The following is a description of a gene set: Signaling by ALK Mouse Gene Set: REACTOME_SIGNALING_BY_ALK species: Mus musculus, and this is the list of marker genes: Alkal2, Ptprz1, Pik3r2, Hdac3, Ptn, Pik3ca, Ep300, Pik3cb, Mdk, Stat3, Hdac1, Ptpn6, Alkal1, Alk, Shc1, Plcg1, Pik3r1